Given this list of marker genes SAT1, PSMD6, AGMAT, AZIN2, PSMA1, SRM, PSMB4, ODC1, PAOX, SMOX (NCBI Gene Id 54498), PSMD2, SEM1, PSMC2, PSMD13, PSMC6, NQO1, PSMA2, PSMA6, PSMB1, AZIN1, SMS, OAZ2, PSMD11, PSMD7, AMD1, PSMA5, OAZ3, PSMD3, PSMD8, PSMD14, ADRM1, PSMD1, PSMC1, PSMB7, OAZ1, PSMA4, PSMC5, PSMB6, PSMA3 (proteasome 20S subunit alpha 3), PSMA7, PSMC3, PSMC4, PSMB3, PSMB5, PSMB2, PSMD12, here is a description of the gene set: studied in species Homo sapiens Three polyamines - putrescine, spermine, and spermidine - are derived from ornithine by decarboxylation and condensation reactions. Arginine is metabolised similarly to form a fourth polyamine, agmatine. Polyamine levels are tightly regulated at the level of the enzyme ornithine decarboxylase (ODC). Reactome Pathway: Metabolism of polyamines part of: Metabolism of amino acids and derivatives